Given this list of marker genes EHMT1, SMYD3, JARID2, SETBP1, KMT2B, SUV39H2, TTLL12 (tubulin tyrosine ligase like 12), PRMT7, NSD1, KMT2A, PRDM8 (PR/SET domain 8), SMYD5, KMT5A, WDR5, NSD2, NSD3, SETD2, PRMT6, DOT1L, PRDM9 (PR/SET domain 9), PRMT8, PRMT1, SETD3, PRMT5, PRDM2, SETDB2, SETD1A, KMT5C, PRMT3, SMYD1, PRDM7, KMT2D, SETD4, EZH1, SETMAR, FBLL1, PRDM16, ASH1L, SETD5, KMT2C, SETDB1, SMYD2, MECOM, SETD1B, PRMT2, KMT5B, PRDM13, CARM1, SUV39H1, PRMT9, SETD7, EHMT2, FBL, NTMT1, EZH2, METTL23, PRDM6, N6AMT1, KMT2E, here is a description of the gene set: Human Gene Set: GOMF_HISTONE_METHYLTRANSFERASE_ACTIVITY studied in species Homo sapiens Catalysis of the reaction: S-adenosyl-L-methionine + histone = S-adenosyl-L-homocysteine + methyl-histone. Histone methylation generally occurs on either an arginine or a lysine residue.